The following is a description of a gene set: Mouse Gene Set: GOBP_INTRACELLULAR_SODIUM_ION_HOMEOSTASIS A homeostatic process involved in the maintenance of a steady state level of sodium ions within a cell. studied in species Mus musculus, and this is the list of marker genes: Scnn1a, Il1a, Atp1b3, Slc8a1, Scnn1b (NCBI Gene Id 20277), Atp1a2, Atp1b1, Agt, Atp12a, Tesc, Nr3c2, Sgk1, Atp4b, C7, Atp4a, Slc1a3, Atp1a4, Tmprss3, Slc9a1, Agtr2, Fxyd2, Atp1a1, Slc12a2, Scnn1g, Atp1a3 (ATPase, Na+/K+ transporting, alpha 3 polypeptide), Spp1, Atp1b2, Umod